The following is a description of a gene set: studied in species Homo sapiens The series of molecular signals mediated by a steroid hormone binding to a receptor. Human Gene Set: GOBP_STEROID_HORMONE_RECEPTOR_SIGNALING_PATHWAY, and this is the list of marker genes: CST11, SRC, ESRRG, BMAL1, USP26, DDX17, TRIP4, TMF1, ESR1, CRY1, TCF7L2, DNAAF4, CYP7B1, VPS18, ESR2, RNF6, CALCOCO1, DDX5, FOXA1, CCDC62, PRMT2, CARM1, SCGB2A2, HMGA2, NR2C1, ZBTB7A, VPS11, DDX54, MED1, CLOCK, HDAC1, RXRB, CREBRF, UBR5, LATS1, PAQR7, TCF21, NR3C2, UFM1, RXRG, JAK2, KDM5D, SKP2, LBH, PDE3A, UBA5, PARP1, DAXX, NR0B1, SAFB2, SIRT1 (NCBI Gene Id 23411), WBP2, KDM3A, CDK12, PADI2, UFSP2, CRY2, IGF1, UFL1, HDAC6, KDM1A, SCGB2A1 (NCBI Gene Id 92174), HEYL, PER1, EP300, FOXH1, PPP5C, RHOXF1, PAQR8, PAK1, YWHAH, PHB1, ISL1, STRN3, PGRMC2, TAF1, DEFA1B, EGLN2, RWDD1, SHQ1, SRARP, GHRHR, ZDHHC7, NEDD4, OR51E2, KDM4C, PIAS2, TRERF1, PPARA, RNF14, RXRA, PPARGC1B, ESRRB, NODAL, ESRRA, TRIM68, HDAC2, ABHD2, TP63, PLPP1, RBFOX2, RHOA, NR2E1, TADA3, NCOR1, PARK7, KANK2, SMARCA4, ERRFI1, DEFA1, CNOT2, NR1D1, PKN1, CNOT9 (CCR4-NOT transcription complex subunit 9), CNOT1, SFRP1, PAGR1 (PAXIP1 associated glutamate rich protein 1), ZMIZ1, NCOR2, FOXP1, GPER1, KMT2D (lysine methyltransferase 2D), PGR, NR3C1, POU4F2, BRCA1, ZNF366, NCOA4, DAB2, TAF7 (NCBI Gene Id 93080), NR4A3, NKX3-1, DEFA3, UBE3A, DDRGK1, VDR, SAFB, NCOA1, LMO3, NR2E3 (nuclear receptor subfamily 2 group E member 3), FSHR, CALR (NCBI Gene Id 811), AR, FKBP4, PMEPA1 (prostate transmembrane protein, androgen induced 1), PPARD, PHB2